The following is a description of a gene set: species: Homo sapiens Human Gene Set: GOBP_PROTEIN_METHYLATION The addition of a methyl group to a protein amino acid. A methyl group is derived from methane by the removal of a hydrogen atom., and this is the list of marker genes: NTMT2, METTL21A, SETD7, EEF1AKMT1, BHMT, SMYD2, ATPSCKMT, SNRPB, VCPKMT, PRMT2, NDUFAF7, SETD2, RAB6A, GSPT1, LCMT1, PRMT1, EEF1AKMT2, ANTKMT, FAM98B, EEF1AKMT3, ICMT, SNRPD3, FAM98A, PRDM12, PRMT5, CSKMT, METTL22, PRMT8, SETD6, EHMT1, EHMT2, ETF1, METTL21C, PRMT7, PCMT1, SETD3, NTMT1, KMT5A, TRMT112, EEF2KMT, METTL18, N6AMT1